The following is a description of a gene set: Genes predicted to be targets of miRBase v22 microRNA mmu_miR_3077_3p in miRDB v6.0 with MirTarget v4 prediction scores > 80 (high confidence targets). Mouse Gene Set: MIR_3077_3P from publication Chen Y, Wang X (PMID 31504780) species: Mus musculus, and this is the list of marker genes: Acyp2 (NCBI Gene Id 75572), Usp9x, Smad6, Spint3, Otx2, Slc27a3, G6pc2, Zfp367, Larp4b, Capn13, Nup98, Tgm6, Zfp936, Ago3, Zfp958, Slc6a4, Fign, Abcf3, Trpv4, Gtf3c2, Ssr1, Ttc9c, Ccdc141, Thsd7b, Ldlrad3, Ubxn7, Hsd17b4, Fam168a, Tnrc18, Grtp1, Bsn, Clasp2